Given this list of marker genes Isoc1, Slc27a5, Crot, Klf1, Nudt12, Pex13, Optn, Cyp7b1, Abca4, Cyp39a1, Abcd1, Abca8b, Akr1d1, Dio1 (deiodinase, iodothyronine, type I), Fads2, Bmp6, Gclm, Scp2, Rbp1, Abca3, Pex6, Pex1, Fads1, Hao1, Amacr, Bcar3, Efhc1, Acsl5, Hsd17b4, Ephx2, Pecr, Aqp9, Pex12, Ar, Abcg8, Idh2, Pex16, Nr3c2, Idi1, Cyp7a1, Tfcp2l1, Nr1h4, Pex19, Abca1, Hacl1, Pxmp2, Paox (NCBI Gene Id 98263), Abcg4, Pnpla8, Serpina6, Hsd17b11, Cyp27a1, Abca2, Fdxr, Sult2b1, Cyp8b1, Nr1i2, Lck, Gc, Abca9, Nr0b2, Rxrg, Hsd17b6, Slc29a1, Pex7, Aldh1a1, Slc23a1, Aldh9a1, Abca5, Ch25h (NCBI Gene Id 12642), Npc1, Abcd2, Sult1b1, Ttr, Slc23a2, Idh1, Slco1a4, Apoa1 (NCBI Gene Id 11806), Prdx5, Acsl1, Soat2, Cyp46a1, Phyh, Slc22a18, Gnmt, Bbox1, Pex11a, Dhcr24 (NCBI Gene Id 74754), Pex26, Rxra, Abca6, Lipe, Slc35b2, Dio2, Agxt, Abcd3, Cat, Retsat, Gstk1, Pipox (NCBI Gene Id 19193), Lonp2, Nedd4, Slc27a2, Atxn1, Gnpat, Mlycd, Hsd3b7, Pex11g, Pfkm, Sod1, Aldh8a1, here is a description of the gene set: Mouse Gene Set: HALLMARK_BILE_ACID_METABOLISM studied in species Mus musculus Mouse genes annotated to HALLMARK_BILE_ACID_METABOLISM based on orthology mappings provided by the Alliance Genome Consortium from publication Howe DG, Blake JA, Bradford YM, Bult CJ, Calvi BR, Engel SR, Kadin JA, Kaufman TC, Kishore R, Laulederkind SJF, Lewis SE, Moxon SAT, Richardson JE, Smith C (PMID 30224793)